The following is a description of a gene set: A process that is carried out at the cellular level which results in the assembly, arrangement of constituent parts, or disassembly of membrane rafts, small (10-200 nm), heterogeneous, highly dynamic, sterol- and sphingolipid-enriched membrane domains that compartmentalize cellular processes. Human Gene Set: GOBP_MEMBRANE_RAFT_ORGANIZATION species: Homo sapiens, and this is the list of marker genes: CAV2, LAT, MIR138-1, FA2H, EMP2, IQGAP1 (IQ motif containing GTPase activating protein 1), FLOT1, DOCK2, MAL, NAXE, GSN, CLN3, MYADM, PTPRC, CAV1, ILK, PACSIN2, COLEC12 (collectin subfamily member 12), LRCH4 (NCBI Gene Id 4034), RFTN1, CD2, DLG1, COL6A1, NPC1, PPT1, S100A10, ANXA2, YJEFN3, ABCA7, CAV3